The following is a description of a gene set: from publication Abbas AR, Wolslegel K, Seshasayee D, Modrusan Z, Clark HF (PMID 19568420) Microarray deconvolution is a technique for quantifying the relative abundance of constituent cells in a mixture based on that mixture's microarray signature and the signatures of the purified constituents. It has been applied to yeast and other systems but not to blood samples. Here we test the ability of this technique to determine the fractions of subsets of memory T cells in peripheral blood mononuclear cell (PBMC) samples. species: Homo sapiens Human Gene Set: GSE11057_NAIVE_VS_CENT_MEMORY_CD4_TCELL_DN Genes down-regulated in comparison of naive T cells versus central memory T cells., and this is the list of marker genes: FXYD7, TSPAN17, ACOT9, RORA, ITPK1, AHR, PEA15, EIF2AK1, FBXL8, TBCB, ITGB1 (NCBI Gene Id 3688), CCR2, SIAH2, TIGIT, PPM1G, GSE1, AUTS2, GPR183, RAPGEF1, ARHGDIA, OSBPL3, LIMS1, ENTPD1, KLHL5, SMAP1, PARP4, FBXW7, DUSP5, ZFYVE28, TIFA, FAM53B, SLC9A9 (solute carrier family 9 member A9), NOD2, IQGAP2, TERF2IP, OGDH, SH3BGRL3, SPSB1, ATP2A2, DEGS1, IQGAP1, SPAG9, ARID5B, MED15, AGFG2, SETD7, RHOU, TSPAN5, PICALM, UBL3, CXCR3, PKM (NCBI Gene Id 8127), LGALS3, RNF214, CCNQ, EEPD1, HNRNPLL, CD2, VCL, COTL1, SNHG33, YWHAH, CTSA, NIBAN1, MPRIP, RNF19B, SURF4, NABP1, PTTG1, LGALS1, NBEAL2, MIAT, ST8SIA1 (ST8 alpha-N-acetyl-neuraminide alpha-2,8-sialyltransferase 1), CLIC1, REEP5, MYO1F, ACTN4, FAR2, HLA-DRB1, DPY19L1, CRIP1, SH3GLB1, RAPGEF2, PRKCD, SSR3, CAPNS1, ARF3, CBLL1, F5, RABGAP1L, PSTPIP1, EIF4EBP2, TRIB1, AFDN, CAST, PHACTR2, SRGN, PAPSS1, TOM1, YWHAQ, AHNAK, SAP30, PFKP, SPPL2A, VDAC1, CCR10, WEE1, PIEZO1, GPRIN3, EPHA4, CD84, ATXN1, ANXA4, EVI2B, PRR5L, ATP2B4, MLF1, FAS (NCBI Gene Id 355, Fas cell surface death receptor), PRDM1, GALNT10, ABCC1, BATF, CHST7, LPP, GPR68, MAP3K5, CD74, NDC80, DENND1B, AKT3 (NCBI Gene Id 26068), IFI16, HERPUD1, RAP2B, RGS3, ZC2HC1A, TP53INP1, IFFO2, CHST12, ZCRB1, CTSC, MAGOH-DT, S100A4, EZR, CTNNA1, VRK2, KLRB1, TUFT1, MYBL1, TAGLN2, BMAL1, CASK, EHD4, TMEM116, CLDND1, C16orf87, GPR65, EFHD2, ZDHHC3, CCR6, AQP3, ARHGAP35, RSU1, MAP3K1, ARHGAP18, AKIRIN2, SLAMF1, RILPL2, EMC3, RAB27A, ADAM8, SPAG1, MICAL2, ELAPOR1, RYR1, SLC6A6, TGFBR3, ELOVL5, NCOA7, IL10RA, MAF, ANXA1, RNF135, TTYH2, MYO5A, KIF1B, SUSD6, PDP1 (NCBI Gene Id 5497), TNFRSF4, CD63, STOM, OSBPL11, SMC6, CD82, CDC42EP3, GOLGA7, CD58, DUSP10, ADAM19, RAB11FIP1